Given this list of marker genes MYC, RAP1GAP2, MAP3K9, ATP1B3, STK38L, ZZZ3, PUM1, CLDN8, MLLT3, HDGFL2, RAB3C, VAMP3, CALN1, TMEM19, LYST, ZNF597, GRHL1, DEFB134, CREB1, MARVELD2, DNM1L, MTDH, KCNA1 (NCBI Gene Id 729214), DLL1, FUT9, CBLB, MAPK1IP1L, HTR2C, PYGB, ELAVL1, APPL1, ZC4H2, KRTAP3-1, PIK3C2A, TAF1A, PRKAA2, MTCL1, ELMOD1, AHCYL2, RDX, ZBTB34, TENT4A, MYF5, HOXC8, HOXB8, HMBOX1, SNIP1, PAPSS2, KCTD16, CELF2, FBXO40, YWHAZ, CTNND2, NCOR1, SOX6, JAKMIP1, CELSR3, XKR6, HMGN4, RHOH, CDK19, CNTNAP1, MYCBP2, NFAT5, ACTL6A, APOB, NEXMIF, PHACTR1, ATP6V0A2, TASOR, ANKS1B, SMPD1, ASCL1, MAPK4, FBXO45, STK39, PTP4A2, BRPF1, ATP11C, PHF6, IFIT1B, CAMSAP2 (NCBI Gene Id 23271), PTPRG, SLC25A13, CD40LG, ZC3H12B, THAP12, NEUROD1, PARD3, SLC25A36, RALA (RAS like proto-oncogene A), STMN2, TFDP2, NDRG1, ARID1B, LCP1, DGKI, MTCL2, TSPYL4, PFKFB1, WIPF3 (NCBI Gene Id 648464), MAN2A2, IL1RAP, THRB, DLG1, GSK3B, MET, ETS1, NHSL1, FAM219A, TOX, TENM1, MIDEAS, CEP55, TMCC3, DENND1B, APH1A, FBXW10B, ADD2, CNTN3, GTF3C2, PTPN4, RFX3, ARID2, BACE1, CADM2, DAAM1, USP15, QDPR, PLEKHA1 (NCBI Gene Id 59338), ASPHD2, CYRIB, FKBP1B, GAS1, MTF1, AMER1, ATAD2B, PIEZO2, ERLIN1, here is a description of the gene set: Genes predicted to be targets of miRBase v22 microRNA hsa-miR-449c-5p in miRDB v6.0 with MirTarget v4 prediction scores > 80 (high confidence targets). Human Gene Set: MIR449C_5P from publication Chen Y, Wang X (PMID 31504780) studied in species Homo sapiens